The following is a description of a gene set: Human Gene Set: REACTOME_SARS_COV_2_MODULATES_AUTOPHAGY SARS-CoV-2 modulates autophagy studied in species Homo sapiens, and this is the list of marker genes: MAP1LC3B, VPS11, VPS16, UVRAG, VPS39, VPS18, TUFM, VPS41, VPS33B, VPS45, VPS33A (VPS33A core subunit of CORVET and HOPS complexes)